Given this list of marker genes CBLN1, ADCY8, IQSEC2, STAU2, KCNB1, GRID2, LILRB2, here is a description of the gene set: Any process that activates or increases the frequency, rate or extent of long term synaptic depression. species: Homo sapiens Human Gene Set: GOBP_POSITIVE_REGULATION_OF_LONG_TERM_SYNAPTIC_DEPRESSION